The following is a description of a gene set: Binding to a carbohydrate, which includes monosaccharides, oligosaccharides and polysaccharides as well as substances derived from monosaccharides by reduction of the carbonyl group (alditols), by oxidation of one or more hydroxy groups to afford the corresponding aldehydes, ketones, or carboxylic acids, or by replacement of one or more hydroxy group(s) by a hydrogen atom. Cyclitols are generally not regarded as carbohydrates. Mouse Gene Set: GOMF_CARBOHYDRATE_BINDING species: Mus musculus, and this is the list of marker genes: Cd209a, Mlec, Gusb, Reg3g, Nectin1, Galnt13, Eng, Mbl2, Klrb1a, Aldoa, Pfkl, Egln1, Reg4, Atrnl1, Galk1, Klri2, Ppp1r3f, Gnpnat1, Pkd1l3 (polycystic kidney disease 1 like 3), Itih1, Lgals2, Colec10, Ppp1r3e, Klri1, Slc2a8, Sftpa1 (NCBI Gene Id 20387), Hexb, Grifin, Clec2h, Lgals8, Galnt1, Adgrl2 (NCBI Gene Id 99633), Cd22, Asgr1, Klrg1 (NCBI Gene Id 50928), P4ha2, H2-Ea, H2-Eb1, Gbe1, Galnt2, Clec4a1, H6pd, Cemip2, Pklr, Fam3c, Aldob, Ppp1r3c, H2-Eb2, Slc2a5, Taldo1, Pfkm, Clec2e, Clec3a, P3h3, Clec4e, Sell, Klra4, Lgals12, Man2b2, Lgals3, Ptn (pleiotrophin), Chid1, Cd72, Galnt5, Colec12, Cd209e, Clec4a4, Mrc1, Ppp1r3b, Chodl, Cd209d, Cilp2, Clec4f, Siglecg, Fcna, Klre1, Klrb1f, Egln2, Gpi1, Klrb1, Zp3, P4htm, Agl (NCBI Gene Id 99740), Klrh1, Man2a1, Calr, Dgcr2, Fbp1, Pomgnt1, Egln3, Asgr2, Galnt14, Galm, Gck, Fuom, Ganab, Klrb1c, Rpia, Siglecf (NCBI Gene Id 233186), Enpp2, Clec1b, G6pd2, Lman1l, Fam3a, Sbp, Galnt16, Klrd1, Pygm, Cd33, Fuca1, Pygl, Clec3b, Galnt3, Ncan, Clec2f, Siglec1 (sialic acid binding Ig-like lectin 1, sialoadhesin), Pla2r1, Clec12a, P4ha3, Cd93, Mbl1, Stbd1, Emc7, Plod1, Hk1 (hexokinase 1), Hk2, Klrg2, Acan, Galnt15, Ugp2, Krt1, Ogfod3, Phyh, Dpm1, Ppp1r3g, Clec2i, Tkt, Cd207, Lman2l, Itln1, Il2, Cd24a, Adgrl3, Lgals1, Apcs, Clec9a, Chil3, Cd302, Cntn1, P4ha1, Ly75, Siglece, Galnt17, Klra6, Cd209f, Lgals7, Klra2, Cd248, P3h2, Galnt10, Endou, Fbxo6, Fbxo2, Manba, Clec14a, Prg4, Clec4a2, Lman1, Adgrl1, Lgals9, Reg3a, Mag (NCBI Gene Id 17136), Lgalsl2, Ogfod1, Hkdc1, Sele, Gyg1, Clec10a, Mgat2, Gfpt1, Clec7a, Clec12b, Plod2, Reg1 (regenerating islet-derived 1), Clec11a, Crybg3, Cd69, Man2c1, Ogfod2, Galnt12, Clec18a, P3h1, Cd34, Frem1, Sftpd, Dbh, Cntn2 (NCBI Gene Id 320300), Gaa, Emcn, Clec5a, Ptx3, Sost, Vtn, Uap1, Pam, Eva1c, Reg3b, Clec1a, Col9a1, Klra8, Pkd1, Ambp, Nomo1, Acr, Pygb, Epm2a, Pkd1l2, Galnt18, C4b, Cln5, Alpk1, Prg2, Igf2r, Ppp1r3d, Fam3d, Pgd, Cd209g, Enpp1, Colec11, Klrk1, Vcan, Galnt6, Gckr, Lgalsl, Prps2, Atrn, Reg3d, Gys1, Clec2g, Prps1, Clec4b1, Bsg, Lgals4, Galnt7 (NCBI Gene Id 26911), Clec4g (NCBI Gene Id 75863), Lman2, Clec4n, Ganc, Canx, Klra1, Nptx2, Clec4a3, Selp, Ppp1r3a, Hk3, Clec2d, Man2b1, Gpcpd1, Fcnb, Reg2, Galnt4, Plod3, Prg3, Rpe, Man2a2, Slc2a3, Os9, Cdipt, Loxl2, Zg16, Clec4b2, Klra7, Fam3b, Cemip, Layn, G6pdx, Cd209b, Mgl2, Mrc2, Clec2l, Klra5, Pgls, Fcer2a (NCBI Gene Id 194559), Cd209c, C4a, Gys2, Bcan, Galnt11, Olr1, Clec4d, Klra3